Given this list of marker genes Fzd9, Ier3, Ap3b1, Letm1, Rhot1, Dynlt1f (dynein light chain Tctex-type 1F), Mtfp1, Cln8, Timm13, Timm22, Maip1, Samm50, Fxn, Trmt10b, Afg3l1, Tomm22, Acaa2, Tomm70a, Mtch2, Agk, Vdac2, Ndufa13, Chchd10, Tmem126a, Afg3l2, Siva1, Pmaip1, Atp5if1, Timm29, Gsk3a, Hk2, Slc25a31, Bcl2l1, Tomm40, Gsk3b, Immt, Ppif, Oxa1l, Gimap5, Chchd6, Pdcd5-ps, Spg7, Camk2a, Bid (NCBI Gene Id 72579), Hspa4, Ppm1k, Bnip3, Bok, Bcl2l2, Apoo, Cnp, Slc25a4, Pink1, Atf2, Gimap3, Slc25a5, Dynlt1b, Eya2, Mtch1, Trp53, Opa1, Micos10, Hsp90aa1, Slc35f6, Slc9a1, Them4, Hip1r, Bad, Timm10, Micos13 (NCBI Gene Id 319512), Bcs1l, Micu1 (mitochondrial calcium uptake 1), Stat3, Bcl2l11, Dnajc11, Mul1, Tmem14a, Apool, Mpv17l, Naif1, Dynlt1c, Tmem102, Dynlt1a, Myc, Uqcc3, Timm9, Bax, Nol3, Timm50, Chchd3, Rhot2, Tafazzin, Gclc, Cox18, Moap1, Cstad, Zfp13, Plscr3, Bak1, Pex5, Bnip3l, Adck1, Slc25a46, Bloc1s2, Tmem11, Stpg1, Bcl2, Romo1, Oma1, Snca, Ghitm, Mfn2, Alkbh7, Cibar1, Pdcd5, here is a description of the gene set: A process that is carried out at the cellular level which results in the assembly, arrangement of constituent parts, or disassembly of a mitochondrial membrane, either of the lipid bilayer surrounding a mitochondrion. species: Mus musculus Mouse Gene Set: GOBP_MITOCHONDRIAL_MEMBRANE_ORGANIZATION